The following is a description of a gene set: studied in species Homo sapiens Formation of the junction between an axon and the glial cell that forms the myelin sheath. Paranodal junctions form at each paranode, i.e. at the ends of the unmyelinated nodes of Ranvier. Human Gene Set: GOBP_PARANODAL_JUNCTION_ASSEMBLY, and this is the list of marker genes: EPB41L3, UGT8, CD9, ANK2, CNTNAP1, GNPAT